Given this list of marker genes Slc38a5, Slc25a13, Slc38a3, Slc32a1, Slc25a12, here is a description of the gene set: Mouse Gene Set: GOMF_AMINO_ACID_MONOATOMIC_CATION_ANTIPORTER_ACTIVITY species: Mus musculus Enables the transfer of a solute or solutes from one side of a membrane to the other according to the reaction: solute(out) + monoatomic cation(in) = solute(in) + monoatomic cation(out). Monoatomic cations include H+, Mg2+, Ca2+, etc.